Given this list of marker genes OLFML2B, IARS1, CYB561, CAST, SP3P, CHD3, PPT1, ZNF202, COL11A1, LRIG1, DET1, RYR2 (NCBI Gene Id 6262), DCTPP1, TMEM204, CAMK2B, PRKAR2A, MAU2, BCKDHA, CD28, MICALL1, HIF1AN, IQCA1, COL14A1, HACD3, MORC4, NAP1L4, HMGCS2, LTB, PRRC2A, KLK3, MRTFB, MCCC2, LIMA1, MAN2B1, ME3, CTSF, CDC37, CPNE3, SORT1, GGA2, ALG3, C1orf159, AGTR2, TOMM34, NAE1, CD248, SGSH, H2AC16, CYP11B1, ATF5, RRAS2, TRIAP1, ABCC10, GMEB2, NDUFAF3 (NCBI Gene Id 375340), NECAP2, PLPP1, GAS1, SBF1, CLUHP3, COL10A1, C10orf95, AMIGO2, PROM1, LTBP3, RND3, ACTN3, EIF3F, PRPF38B, CES2, SGK2, FGF9, IFNG, CHMP7, CD320, GPRC5D, GCAT, SYNGR4, ESF1, CBR3, GP9 (NCBI Gene Id 2815), DOHH, LRRC20, CADPS (calcium dependent secretion activator), TRPV2, NBEAL2, SRY, DNAH9, SLC12A7, DNAL4, EVI2A, METAP1, FAM174B, HUNK, OFD1, ZNF571, ALOX15B, EPHA1, HGH1, CUL2, ATP6V1B1, TMEM161A, AP5S1, GLB1L2, ZAP70, SH2B1, ASCC3, LPIN1, ZNF587, NCKIPSD (NCK interacting protein with SH3 domain), EIF2B3, GOT2, GIMAP5, PILRB, ATP11A, HSF1, PHC1, GPR171, ZNF14, BCS1L, SEMG1, GSTP1, SUV39H1, SRPRB, ITGB1, PRP4K, CFAP410, MGLL, CAMSAP2, TESK1, CDR2, SRRT, KAT2A, CHMP6, C6orf62, OGFOD3, SCML1, RXYLT1, ELOA2, MBL2, CAD, HNRNPA3, RAPGEF6, CTSH, TNFRSF4, PEBP1, UGT8, DCAF11, INPP4B, USP36 (NCBI Gene Id 80160), SIVA1, F2RL2, SFI1, ORC6, STOM, SETD4, PEA15, SMPD2, PIGN, PRKD3, FOCAD (focadhesin), MYBL1, FAM182A, IL13RA2, SLC66A3, EIF2D, TAF5L, RASGRP2, MAT2A, SLC6A4, TMEM33, TSPAN14, SDR39U1, EML3, SEMA3G, ELOVL4, CD82, SUPV3L1, KCTD5, ARHGEF10, ACVR2A, MYBPC1, POLQ, DPY19L2P2, GGA1, WDR18, ADAT1, RAB40A, LARP1, TASOR, IGHV5-78, DIAPH2, CNDP2, PLEKHA5, HOOK2, CNNM1, RPSA, JHY, RGS4, here is a description of the gene set: Human Gene Set: GSE3982_BASOPHIL_VS_CENT_MEMORY_CD4_TCELL_DN In the present study we used Affymetrix oligonucleotide microarrays to produce gene transcription profiles for the major leukocyte types in humans. This comprehensive dataset enabled us to not only establish which genes were expressed in each leukocyte type, but also which genes were expressed in each subset after activation. The used of a comprehensive dataset of gene profiles from all the major human leukocyte subsets enabled a novel and powerful means for identification of genes associated with single leukocyte subsets, or different immune paradigms. Genes down-regulated in comparison of basophils versus central memory CD4 T cells. species: Homo sapiens from publication Jeffrey KL, Brummer T, Rolph MS, Liu SM, Callejas NA, Grumont RJ, Gillieron C, Mackay F, Grey S, Camps M, Rommel C, Gerondakis SD, Mackay CR (PMID 16474395)